The following is a description of a gene set: We used microarrays to compare interferon-alpha (IFNa)- and interferon-gamma (IFNg)-stimulated genes under an equivalent biological input. The goal was to compare IFNa- and IFNg-stimulated genes, as well as to identify common and distinct sets of type I and II ISGs. species: Homo sapiens from publication Liu SY, Sanchez DJ, Aliyari R, Lu S, Cheng G (PMID 22371602) Human Gene Set: GSE35825_UNTREATED_VS_IFNA_STIM_MACROPHAGE_UP Genes up-regulated in bone marrow-derived macrophages: untreated versus stimulated by interferon alpha., and this is the list of marker genes: MED22, B3GNT8, RIPOR1, F8A1, EIF2AK3, ELMO2, FAHD1, TAFAZZIN, TGFBRAP1, PNPO, CNPY3, PREX1, FAM117B, SESN2, SETDB1, RXRA, ANKRD13D, SSBP3 (NCBI Gene Id 55126), SESN1, FNBP1, DPYSL2, MAZ, TRMT2A, MYO7A, MAVS, SMAP2, CD99L2, ANGEL2, TPRA1, NEDD9, SMAD5, SUFU, LRRK1, POLG2, PLA2G15, NT5C2, ANKRD10, LFNG, TRUB1, NAPB, RASGRP3, DUSP22, FOXRED2, RASSF3, FBXO31, AKAP1, GBA2, SIPA1, USP20, GALNT11, EMILIN1, DEAF1, NT5DC3, DLG4, RASA3, MATN2, PAOX, KDSR, CCDC9, SLC17A9, SLC45A4, USP36 (ubiquitin specific peptidase 36), TMEM126B, PRKCH, CEP57, ANKMY2 (NCBI Gene Id 96008), TMEM186, ABL1, GPR157, CHKA, TMEM129, SETX, ADIPOR2, TSEN2, TMEM86A, MIGA1, TPCN1, PCGF2 (NCBI Gene Id 7703), TTC7A, TWF2, JOSD1, ENGASE (NCBI Gene Id 64772), FAM174A, ZFAND2A, RAB3D, SLC25A30, MDP1, MPV17, ORC5, RASSF7, TRIM65, TARBP1, ABCD4, KLHDC2, GGA2 (golgi associated, gamma adaptin ear containing, ARF binding protein 2), TRIAP1, RGS2, MLH3, MFSD11, RALGPS2, DCAF4 (NCBI Gene Id 26094), ING2, LACTB2, RETREG3, ZBTB1, PAQR7, NSF, KLHL22, DHCR7 (7-dehydrocholesterol reductase), MAT2B, MTMR12, KCNK6, HS1BP3, SUSD3, IRAG2 (inositol 1,4,5-triphosphate receptor associated 2), FAM110A, GNA11, BTBD2, CNTROB, BBS7, DNMT3A, RAB3IL1, NCEH1, VAMP1, GAB3, UVRAG, CTNS, PHF12, ACSS1, MID1IP1, INPP5D, FADD, OIT3, ELF2, ENTPD4, ADI1, UCK1, MICAL1, LIFR, FLI1, MBLAC2, NRROS, SPICE1, TBC1D14, HDAC8, AAGAB, SNTB2, ACOT2, ADO, PHF7, RMND5A, TMEM81, SMC3, SGPP1, TRERF1, PSRC1, ARRB1 (arrestin beta 1), DHDH, DNAJC4, NBEAL2, LRP5, MYO1F, TMEM64, TRAPPC12, KYAT1, DEPDC5, CORO1C, ACBD5, SLC37A2, FAM78A, AGAP3, PGP, BTBD1